Given this list of marker genes FAM149A, MTIF3, RBPJ, MORC2, CD300LG, SYNJ2, SLC35D2, NOTCH4, TBC1D21, CCL13, ARHGAP21, SPO11, WDFY3, KCMF1, WDPCP, ZBTB20, SDHA, ERCC6L, RAMP1, MAN1A2, IWS1, SLC25A24, IL17RD, IQSEC1, NOP2, RBM47, SLC16A2, OPN3, ARAP1, ZNF367, MDH1, SH3GL3, SCAMP2, POLR2G (RNA polymerase II subunit G), STARD3NL, ZNF710, HECTD4, SDAD1, TRIM27, RAP1GAP, GCSAM, DNAJC1, INPP4A, ERC1, SLC22A5, MORN1, ORAI1, IKZF2, CCNB1IP1, TXNDC5, GALNT7, ADCK5, SMARCD1, NIBAN3, PRKX, PLPP1, SLC9A9, KLRC3, ATG9A (autophagy related 9A), CNDP1, SPINT4, C11orf54, SYNPO2, ZSCAN20 (NCBI Gene Id 96159), SLF2, LIPA, LMNTD2, BRD2, UPK3B (uroplakin 3B), PIGF, LEPROTL1, DBN1, TENT5C, STBD1, EFCAB3, EPRS1, SLC9A3, SPRR3, APOM, ORM2, CARMIL2, ALDOC, CARD10, VWF, GNA15, ATP8B2, ENPP4, PRPF8, SMCO4, DSCAML1, CAMK1D, FNIP2, AMTN, TTLL4, FBXO6, P2RY14 (NCBI Gene Id 9934, purinergic receptor P2Y14), ATG16L1, FAM91A1, IGIP, STARD10, ACO1, DZIP3, IL36G, PRKCI, NAAA, ERG28, TXNDC16, TIAM1, APOBR, SELENOS, DHX32, GUSB, HADHB, CYP11B1, PLEKHN1, ARSB, COL20A1, SEPSECS, MFN2, LRRC1, MAGED1, RNF157, FARP2, SLC25A44, PHKA2, SLC12A3, NDUFC2, ARID1B, DNASE1L3, MINDY3, CORO7, BRSK1, SLC12A7, METTL22, SYNE1, SLC6A19, OXCT1, STX17, SERPINC1, UROS, MBTPS1, RPS6KA2, ATP1B3, UNC119B, KCNQ1OT1, PADI3, ELAC2, CDK1, SLC35B1, PHLDA2, DOCK5, GPR135, VHL, SH3TC1, SLC25A6, NOMO1, CYB5D2, CCR9, CD36, TBCA, MANBA, GUCA1A, GCSH, CLNK, SZT2, POLR2I, GFOD1, RTRAF, ABCA3, GABRR2, HCST, TUBB6, FFAR4, IFT43, PPEF2, DKK3 (NCBI Gene Id 51583), MOGAT2, PTGIS, LRRC28, CXXC5, RPN2 (NCBI Gene Id 6185), SIGMAR1, PALS2, SETX, GTF3C4, MYO19, CCDC125, NUP93, NPNT, TRIP6, TXNDC8 (thioredoxin domain containing 8), TMEM74B, LGR5, CD99L2, RNF217, TNFRSF21, VPS37C, SCFD2, LRRCC1, PRR14L, here is a description of the gene set: species: Homo sapiens Genes down-regulated in day 40 memory B cells versus day 40 germinal center B cells. Human Gene Set: GSE11961_MEMORY_BCELL_DAY40_VS_GERMINAL_CENTER_BCELL_DAY40_DN To obtain insight into the genetic basis of the increase of functional activity of memory B cells over time, we compared the gene expression profiles of day 7 and day 40 NP-specific/IgG1 memory B cells, GC B cells and plasma cells in immunized WT mice and naïve B cells, before and after activation in vitro. from publication Kaji T, Ishige A, Hikida M, Taka J, Hijikata A, Kubo M, Nagashima T, Takahashi Y, Kurosaki T, Okada M, Ohara O, Rajewsky K, Takemori T (PMID 23027924)